Given this list of marker genes Smad3, Smad1, Smad7, Smad4, Smad9, Smad5 (SMAD family member 5), Smad2 (NCBI Gene Id 319898), Smad6, here is a description of the gene set: A protein complex composed of SMAD family proteins, a transcription factor complex which binds to the promoters of target genes and recruits co-activators and histone acetyltransferases, facilitating transcription. Phosphorylation of the non-SMAD4 subunit(s) enables binding of SMAD4 to form heteromeric complexes that enter the nucleus to initiate gene transcription. DNA-binding specificity is conferred by other transcription factors binding to SMAD complexes. Interactions with coactivators or corepressors modulate their transcriptional activity. Can be heterotrimeric or heterodimeric. Mouse Gene Set: GOCC_HETEROMERIC_SMAD_PROTEIN_COMPLEX studied in species Mus musculus